The following is a description of a gene set: Human Gene Set: FXR_IR1_Q6 Genes having at least one occurrence of the motif GGGTBAATRACCY in the regions spanning 4 kb centered on their transcription starting sites. This matches the RXRA transcription factor binding site V$FXR_IR1_Q6 (v7.4 TRANSFAC). species: Homo sapiens, and this is the list of marker genes: OVGP1, ARF3, TNRC6A, MACF1, SSBP3, GDNF, NPAS2, NDRG2, DAB2, FABP6, ZMYND12, RAB5C, BCL9L, NBR2, FOXA1, ABCB11, ERF, SERTAD4, FGFBP3, DLX3, WBP2NL (NCBI Gene Id 164684), FHL3, ID3, CA14, HOXD3, BRCA1, ENSG00000291228, ADO, NPTX2, SMAD3, RAB3C (NCBI Gene Id 115827), TRMT10A, PHOX2B, BMI1, CLC, ST7, IFRD2, TBCC, SOX15, LIN28A, ARF6, TTL, SLC13A5, ZIC2, NOS1AP, PPP2R2B, DTD2, RNASE4, AK9, TMEM256, HTN1, PAK6, SCNN1A, KCNIP2, NOL4L, MRPS18B, FGF6, HES1, CITED2, RARA, MED26, HES7 (hes family bHLH transcription factor 7), GRIK3, ZNF148, IQSEC1, SPMIP9, GPR12, SOX5, RNF14, GPRIN3, VAMP2, TTC12, LTBP1, FRMD5, AGAP2, VAMP1, TPD52L3, FCHSD2, NR6A1, WFIKKN2 (NCBI Gene Id 124857), DMD, NONO, HOXA9, GPATCH11, FLI1, ADCY8, MIR22HG, APP, KITLG, ABR, INSM1, EEF1A1, EIF5, KLHL13, HSPB2, NR0B2, ZMIZ1, PPCS, KCTD5, WDR81, ALDH1A2, LIMK2, VEGFA, HMGB2, R3HDM1, SPATA20, DDAH2, DLGAP4, PDC, EBF2, SCAMP5, CLDN7